Given this list of marker genes PDZK1, ISG15, EBPL, E4F1, ITGAE, MANSC1, RALGDS, ARPC5, KIF4A, PGM3, AUP1, TMEM51, ATP1B1, TIMM21, SUCLG2, TGM2, COA3, VAPB, PGM1 (NCBI Gene Id 5236), PPT1, YIPF5, FERMT2, NCAPG2, MCRIP1, HAX1 (NCBI Gene Id 10456), MRPS34, UFM1, UBE2I, MRTO4, IST1, ERGIC1, CENPF, SRSF9, FBXO17, SLA, ARPC3, UBL7, SLC12A1, SERP1, TGIF1, PRMT5, PPME1, SQOR, COLGALT1, FN1, LIN28B, CDC25B, PER3, GOT2, RPL22, EDN2, SH3BGRL3, BET1L, DHFR, ATP6V1A, RPN2, PLOD3, HMG20B (NCBI Gene Id 10448), here is a description of the gene set: from publication Jiang Y, Zhang W, Kondo K, Klco JM, St  Martin TB, Dufault MR, Madden SL, Kaelin WG Jr, Nacht M (PMID 12692265) Genes up-regulated in 786-0 cells (renal carcinoma, RCC) by hypoxia and in the absensce of VHL. The von Hippel-Lindau tumor suppressor, pVHL, is a key player in one of the best characterized hypoxia signaling pathways, the VHL-hypoxia-inducible factor (VHL-HIF) pathway. To better understand the role of VHL in the hypoxia signaling pathways of tumor cells, we used serial analysis of gene expression (SAGE) to investigate hypoxia-regulated gene expression in renal carcinoma cells (786-0), with and without VHL. The gene expression profiles of the cancer cells were compared to SAGE profiles from normal renal proximal tubule cells grown under both normoxia and hypoxia. The data suggest that the role of VHL as a tumor suppressor may be more complex than previously thought. Further, the data reveal that renal carcinoma cells have evolved an alternative hypoxia signaling pathway(s) compared with normal renal cells. These alternative hypoxia pathways demonstrate VHL-dependent and VHL-independent regulation. The genes involved in such pathways include those with potential importance in the physiological and pathological regulation of tumor growth and angiogenesis. Some of the genes identified as showing overexpression in the cancer cells, particularly those encoding secreted or membrane-bound proteins, could be potential biomarkers for tumors or targets for rational therapeutics that are dependent on VHL status. Human Gene Set: JIANG_HYPOXIA_CANCER studied in species Homo sapiens